The following is a description of a gene set: A multimeric enzyme complex, usually a dimer or an octamer, that catalyzes the conversion of 2-phospho-D-glycerate to phosphoenolpyruvate and water. studied in species Mus musculus Mouse Gene Set: GOCC_PHOSPHOPYRUVATE_HYDRATASE_COMPLEX, and this is the list of marker genes: Eno3, Eno4, Eno1b (enolase 1B, retrotransposed), Eno2, Eno1